Given this list of marker genes GFRA2, CNTN2, FYN, COL6A5 (NCBI Gene Id 256076), PRNP, CACNA1C, CACNA1H, SPTB, CACNA1S, NCAM1, ST8SIA2, COL6A2, CACNA1G, HRAS, PTPRA, COL6A1, MAPK3, CREB1, COL9A2, NRTN, SPTBN2, CACNB3, SPTAN1, KRAS, COL3A1, COL4A1, ST8SIA4, CACNB4, SPTBN1, CACNB1, CACNA1I (calcium voltage-gated channel subunit alpha1 I), NRAS, PTK2, SPTA1, GRB2, COL4A2, COL2A1, CACNA1D, COL5A3, SOS1, COL6A6, COL9A3, COL6A3, GFRA1, SPTBN4, COL5A1, AGRN, RPS6KA5, COL4A4, COL4A5, GFRA4, COL9A1, MAPK1, GDNF, FGFR1, COL5A2, SPTBN5, NCAN, ARTN, CACNB2 (calcium voltage-gated channel auxiliary subunit beta 2), COL4A3, PSPN, SRC, here is a description of the gene set: species: Homo sapiens NCAM signaling for neurite out-growth Human Gene Set: REACTOME_NCAM_SIGNALING_FOR_NEURITE_OUT_GROWTH